Given this list of marker genes Tsc22d1, Arl1, Lgals1, Sp140l2, Hexb, Ywhae, Cd44, Dusp5, Ube2m, Tle5, Zfp36 (NCBI Gene Id 22695), Ergic1 (NCBI Gene Id 67458), Rilpl2, Susd3, Ptma, Antkmt, Tubb2a, Plin3, Tagln2, Tyrobp, Mcl1, Cd79a, Ptpn1, Hck, Tgm2, Ahnak, Ubb-ps, Pepd, Ppp2r5c, Tmem160, Cd9, Rpl13a, Gnb1, Prr13, Jchain, Fos, Krt14, Mzb1, Ctsd, Fcgrt, Itm2c, H2-Q6, Myadm, Calhm2, Mir24-2, Psmd8, Ms4a6c, Atp2b1, Nfil3, Snrpc, Cd36, Cst3, Kdm6b, Tppp3, Arhgdia, Jund, Ctla4, Ctsh, Cyba, Mbd3, BC004004, Spib, Crip2, Rhob, Lgmn, Plaat3, Crlf2, Vim, Comt, Nap1l1, Twf1 (twinfilin actin binding protein 1), Rap1a, Anxa1, Psap, Acly, Tcf3, Calm1, Apoe, Ctsb (cathepsin B), Emp3, Gm15987, Gns, Rnaset2b, Ier2, Anxa5, Psmd14, Tmem234, Anxa2, Prss23, Plp2, Cmtm7, Pafah1b3, Pdlim1, S100a6, Ptprj, Tmsb10, Crip1, Aldh2, Gas7, Ifi27, Sf3b4, Tcirg1, Itm2b, Vcf1, Ebna1bp2, Pmaip1, Atf3, Socs3, Npc2, Clic4, Reep5, Ndufb8 (NCBI Gene Id 67264), Lyz2, Ccnd2, Bsg, Capg, Mcu, Cfl1, Klf2, Rtn4, P2ry12, Stk38, Grn, Sparc, Lmna, here is a description of the gene set: from publication Tabula Muris Consortium (PMID 32669714) Mouse Gene Set: TABULA_MURIS_SENIS_SUBCUTANEOUS_ADIPOSE_TISSUE_B_CELL_AGEING species: Mus musculus